Given this list of marker genes AKR1C1, SLC27A5, HSD17B10, MALRD1, OSBPL2, CYP39A1, OSBPL3, FGFR4, ACAA1, AKR1C4, CES1, ACOX2, HSD3B7, CYP27A1, NR1D1, BAAT, ACOT8, CYP7A1, SLC27A2, ATP8B1, ABCB11, STARD4, GBA2 (NCBI Gene Id 57704), OSBPL6, CYP7B1, CYP8B1, AMACR, ABCD3, OSBPL9, UGT2A2, LEP, NR5A2, ERRFI1, PROX1, OSBPL1A, ARV1, MIR33A, SULT2A1, STAR, FGF19, PANK2, KIT, AKR1D1, OSBPL7, UGT2A1, CYP46A1, NR1H4, SIRT1, OSBP, SCP2, NPC1, here is a description of the gene set: Human Gene Set: GOBP_BILE_ACID_METABOLIC_PROCESS The chemical reactions and pathways involving bile acids, a group of steroid carboxylic acids occurring in bile, where they are present as the sodium salts of their amides with glycine or taurine. species: Homo sapiens